The following is a description of a gene set: part of: Co-inhibition by PD-1 The PD-L1(CD274)/PD1 pathways play a pivotal role in the regulation of normal T cell function as well in diseases like Cancer. It is a major co-inhibitory checkpoint signalling that regulates T cell activities and maintains immune homeostasis thus preventing autoimmunity in normal physiology and this same machinery is hijacked in disease like cancer to evade T-cells immunity against cancer cells. Under normal physiological conditions, PDL-1 (CD274) binds with its receptor PD1 and inhibits TCR and costimulatory signalling, thus inhibiting T cell activation. This regulation helps in the maintenance of immune tolerance. PDL1 (CD274) is normally expressed by antigen presenting cells APCs but it's also found to be expressed by non-immune cells like cancer cells. Expression of PDL1 is tightly controlled at epigenetics, transcriptional, translational and post translational level in normal condition but cancer cells utilise this regulation to induce PDL1 expression on its surface.. species: Homo sapiens Reactome Pathway: Regulation of PD-L1(CD274) expression, and this is the list of marker genes: CUL1, H2BC14, H2BC3, H2BC9, RPS27A, LEF1, IRF1, PSMB3, H2AB1, CUL3, MYCN, H2AC14, H2AC4, PDCD1, TEAD3, PSMD1, NEK2, PSMA2, H2BC12L, RBBP7, H2BC1, PSMD13, CSNK2A2, PSMB1, MIR424, PSMC1 (proteasome 26S subunit, ATPase 1), SPOP, PRKAB2, ADRM1, PSMD7, SEM1, KMT2A, RPN2, TNRC6C, MIR429 (NCBI Gene Id 554210), SKP1, PSMA3, PSMD14, MIR152, EPAS1, PSMD8, DDOST, DERL1, CSNK2A1, ATF3, YAP1, H2BC13, PSMC2, PSMB6, NFE2L2, PSMC3 (proteasome 26S subunit, ATPase 3), UBC, MIR93, TEAD2, SEL1L, TMEM258, H3C1, CCND1, TNRC6B, OS9, RBBP4, PRKAB1, H2BC21, ERLEC1, ERLIN1, RBX1, B3GNT3, STAT3, MIRLET7A1, DERL2, RBBP5, JUN, STT3A, MIB2, ERLIN2, PRKAA2, DAD1, PRKAG3, RNF185, PSMB7, FOSB, CSNK2B, MAGT1, FOS, H2BC11, AGO3, TEAD4, AGO4, H3C15, DERL3, UBB, H2BC4, H2AX, PRKAA1, MIR34C, H2AC7, EZH2, H4C1, PSMC5, PSMC4, MIR200C, EP300, TCF7L2, VCP, H2AJ, JAK1, PSMA4, RNF5, MIR142, H2AC18 (H2A clustered histone 18), MIR34B, CDK4, PSMA6, JUND, H3-3A, MYC, PSMA7, PSMB4, OST4, TNRC6A, CD274, MIR140, CTNNB1, STAT1, H2BC26, TEAD1, GSK3B, DPY30, SUZ12, NFKB2, HIF1A, STT3B, PSMA5, WWTR1 (WW domain containing transcription regulator 1), PDCD1LG2, TCF7L1, H2BC5, ASH2L, OSTC, MIR200B, AGO1, H2BC17, YWHAG, PRKAG1, PSMD2, TUSC3, BRD4, COPS5, PSMB2, RELA, H2AZ2, TCF7, PRKAG2, PSMD3, BTRC, PSMD12, MIR34A, RPN1, KMT2C, NFKB1, PSMD6, H2AC6, AGO2, MOV10, MIR148A, MIR340, UBA52, PSMC6, H2AC20, PSMD11, MIR138-1, CREBBP, H2BC15, EED, PSMA1, WDR5, PSMB5, H2BC12